The following is a description of a gene set: part of: Signal Transduction This event has been computationally inferred from an event that has been demonstrated in another species.<p>The inference is based on the homology mapping from PANTHER. Briefly, reactions for which all involved PhysicalEntities (in input, output and catalyst) have a mapped orthologue/paralogue (for complexes at least 75% of components must have a mapping) are inferred to the other species. electronically inferred by orthology from the curated human pathway Reactome Pathway: Intracellular signaling by second messengers species: Mus musculus, and this is the list of marker genes: Fgf20, Calm1, Psma6, Psma2, Pde1b, Ubb, Pik3ap1, Psmb7, Klb, Akt1s1, Foxo4, Btc, Ring1, Psmc1, Mbd3, Rraga, Esr1, Trim27, Lamtor5, Psma7, Pip4k2c, Cbx4, Sall4 (NCBI Gene Id 99377), Prkar2b, Il33, Psmd13, Maf1, Prkcg, Phlpp2, Cdkn1b, Frs2, Psmc5, Pik3cb, Ntf5, Egfr, Rbbp4, Irs2, Scmh1, Lamtor4, Nrg3, Myd88, Casp9, Lamtor2, Flt3l, Prkacb, Mta2, Fgf4, Rictor, Fgf6, Cd80, Trat1, Psma4, Fgf10, Cd28, Irak1, Rps27a, Nr4a1, Mapk3, Camkk1, Il1rl1, Fgf2, Fgf17, Esr2, Sgk1, Tnks2, Ppp2r5a, Phlpp1, Prkca, Pip5k1c, Kit, Fgf23 (NCBI Gene Id 64654), Pdpk1, Rheb, Rragc, Bdnf, Pik3r5, Cbx6, Rac2, Csnk2b, Ins2, Erbb4 (erb-b2 receptor tyrosine kinase 4), Fgf22, Fgf1, Prkaca, Adcy8, Psmb4, Erbb2, Adcy5, Areg, Psmc2 (NCBI Gene Id 19181), Psmb5, Ppp2r5b, Psmc3, Fgf8, Psmd7, Tgfa, Cbx2, Cd19, Them4, Psmd6, Icos, Ins1, Foxo6 (forkhead box O6), Rnf146, Cbx8, Kl, Mta1, Ezh2, Adcy7, Gab1, Fgfr1, Ier3, Prkar1b, Pdgfa, Bmi1, Pde1c, Strn, Rps6kb2, Fyn, Vav1, Psmd1, Psmc4, Grb2, Cdkn1a, Fgf16, Ppp2r1b, Psmb6, Pip5k1a, Camkk2, Otud3, Lck, Pdgfb, Psmd12, Psma3, Epgn, Psma1, Psmc6, Fgf15, Wwp2, Psma5, Irs1, Rbbp7, Fgf7, Pdgfrb, Ppp2r5d, Fgf5, Hgf, Phc1, Pik3r2, Kitl, Lamtor1